Given this list of marker genes Capn3, Tdg-ps, Slc6a4, Scn3a, Atp1a2, Slc34a2, Atp1a1, Tdg, Pdxk, Scn8a, Amelx, Scn9a, Scn1a, Scn2a, here is a description of the gene set: species: Mus musculus Binding to a sodium ion (Na+). Mouse Gene Set: GOMF_SODIUM_ION_BINDING